The following is a description of a gene set: Human Gene Set: PALOMERO_GSI_SENSITIVITY_DN Down-regulated genes associated with sensitivity and resistance to gamma-secretase (GSI) in T-cell acute lymphoblastic leukemia (T-ALL) cell lines. studied in species Homo sapiens Gain-of-function mutations in NOTCH1 are common in T-cell lymphoblastic leukemias and lymphomas (T-ALL), making this receptor a promising target for drugs such as gamma-secretase inhibitors, which block a proteolytic cleavage required for NOTCH1 activation. However, the enthusiasm for these therapies has been tempered by tumor resistance and the paucity of information on the oncogenic programs regulated by oncogenic NOTCH1. Here we show that NOTCH1 regulates the expression of PTEN (encoding phosphatase and tensin homolog) and the activity of the phosphoinositol-3 kinase (PI3K)-AKT signaling pathway in normal and leukemic T cells. Notch signaling and the PI3K-AKT pathway synergize in vivo in a Drosophila melanogaster model of Notch-induced tumorigenesis, and mutational loss of PTEN is associated with human T-ALL resistance to pharmacological inhibition of NOTCH1. Overall, these findings identify transcriptional control of PTEN and regulation of the PI3K-AKT pathway as key elements of the leukemogenic program activated by NOTCH1 and provide the basis for the design of new therapeutic strategies for T-ALL. from publication Palomero T, Sulis ML, Cortina M, Real PJ, Barnes K, Ciofani M, Caparros E, Buteau J, Brown K, Perkins SL, Bhagat G, Agarwal AM, Basso G, Castillo M, Nagase S, Cordon-Cardo C, Parsons R, Zúñiga-Pflücker JC, Dominguez M, Ferrando AA (PMID 17873882), and this is the list of marker genes: RAB29, DNAAF9, APOL6, ZNF426, TUG1